Given this list of marker genes PPP3CA, ECI2, TPM4, ANXA2, UBE3A, ANXA8L1, MAD1L1, MOK, GARS1, NTHL1, FUBP3, RAP2A, here is a description of the gene set: from publication Xu K, Guidez F, Glasow A, Chung D, Petrie K, Stegmaier K, Wang KK, Zhang J, Jing Y, Zelent A, Waxman S (PMID 16140955) Genes down-regulated in NB4 cells (acute promyelocytic leukemia, APL) by tretinoin alone. Differentiation induction is an effective therapy for acute promyelocytic leukemia (APL), which dramatically responds to all-trans-retinoic acid (ATRA). Recent studies have indicated that combinatorial use of retinoid and nonretinoid compounds, such as histone deacetylase inhibitors, arsenics, and PKA agonists, has higher therapeutic value in this disease and potentially in other malignancies. In a screen of 370 compounds, we identified benzodithiophene analogues as potent enhancers of ATRA-induced APL cell differentiation. These effects were not associated with changes in global histone acetylation and, for the most potent compounds, were exerted at very low nanomolar concentrations, and were paralleled by enhancement of some, but not all, ATRA-modulated gene expressions. Investigating the mechanism underlying the effects of these drugs on ATRA-induced APL cell differentiation, we have shown that benzodithiophenes enhance ATRA-mediated dissociation and association of corepressor N-CoR and coactivator p300 acetyltransferase, respectively, with retinoic acid receptor (RAR) alpha proteins. These data suggest that benzodithiophenes act at the level of receptor activation, possibly by affecting posttranslational modification of the receptor (and/or coregulators), thus leading to an enhancement in ATRA-mediated effects on gene expression and APL cell differentiation. Given the specificities of these low benzodithiophene concentrations for PML-RARalpha and RARalpha, these drugs may be useful for combinatorial differentiation therapy of APL and possibly other acute myelogenous leukemia subtypes in which the overall ATRA signaling is suppressed. Human Gene Set: XU_RESPONSE_TO_TRETINOIN_DN studied in species Homo sapiens